Given this list of marker genes Ccng1, Pmaip1, Zmat3, Perp, Trp53inp1, here is a description of the gene set: from publication Jones NC, Lynn ML, Gaudenz K, Sakai D, Aoto K, Rey JP, Glynn EF, Ellington L, Du C, Dixon J, Dixon MJ, Trainor PA (PMID 18246078) Genes up-regulated in E8.5 embryos with heterozygous knockout of TCOF1 compared to wild type. Treacher Collins syndrome (TCS) is a congenital disorder of craniofacial development arising from mutations in TCOF1, which encodes the nucleolar phosphoprotein Treacle. Haploinsufficiency of Tcof1 perturbs mature ribosome biogenesis, resulting in stabilization of p53 and the cyclin G1-mediated cell-cycle arrest that underpins the specificity of neuroepithelial apoptosis and neural crest cell hypoplasia characteristic of TCS. Here we show that inhibition of p53 prevents cyclin G1-driven apoptotic elimination of neural crest cells while rescuing the craniofacial abnormalities associated with mutations in Tcof1 and extending life span. These improvements, however, occur independently of the effects on ribosome biogenesis; thus suggesting that it is p53-dependent neuroepithelial apoptosis that is the primary mechanism underlying the pathogenesis of TCS. Our work further implies that neuroepithelial and neural crest cells are particularly sensitive to cellular stress during embryogenesis and that suppression of p53 function provides an attractive avenue for possible clinical prevention of TCS craniofacial birth defects and possibly those of other neurocristopathies. Mouse Gene Set: JONES_TCOF1_TARGETS studied in species Mus musculus